The following is a description of a gene set: The chemical reactions and pathways involving alcohols, any of a class of compounds containing one or more hydroxyl groups attached to a saturated carbon atom. species: Mus musculus Mouse Gene Set: GOBP_ALCOHOL_METABOLIC_PROCESS, and this is the list of marker genes: Gpd2, Coq2, Aldh3a2, Acer3, Gfi1, Hmgcs1, Rdh8, Retsat, Hao1 (hydroxyacid oxidase 1, liver), Mapk1, P2ry6, Bmp6, Akr1c18, Gde1, Dgkq, Pmvk, Sphk1, Npc1, Fgfr4, App (amyloid beta precursor protein), Ces1a, Degs2, Gk5, Adh5, Ippk, Pcbd1, Coq3, Acadvl, Pgp, Rdh16, Aldh3b1, Tm7sf2, Saa1, Bmp5 (NCBI Gene Id 12160), Dgat1, Ttc39d, Itpkb, Sult2a8, Akr1cl, Hmgcs2 (NCBI Gene Id 269467), Srebf1, Smpd1, Hsd11b2, Srd5a3, Ptafr, Acer1, Sdr16c5, Fgl1, Cbr4, Fgf1, Tpk1, Ldlr, Park7, Rdh5, Erlin2, Errfi1, Chka, Stard4, Nfkb1, Disp3, Akr1b1, Rdh14, Ces1e, Gnai1, Abca2, Sqle, Vldlr, Inppl1, Hsd17b7, Cebpa, Idh2, Wnt4, Dpm1, Pnlip, Rdh9, Sult2a5, Cyp39a1, Sult1e1, Ephx2, Lmf1 (lipase maturation factor 1), Cftr, Ip6k1, Apoa1, Dolk, Sgpp2, Mvd, Apob, Aldh1b1, Rdh12, Lipe, Nudt3, Gdpd3, Myof, Cyp1a1, Cyp27a1, Sgpp1, Gk2, Ces2e, Rpe65, Pcsk9, Rbp1, Pth, Lss (lanosterol synthase), Rdh10, Ntsr1, Cd244a, Adh4, Npc2, Star, Cyp1a2, Rbp4, Impa2, Plpp1, Ip6k3, H6pd, Lepr, Cyp27b1, Rdh19, Impa1, Aldh2, Abcg1 (NCBI Gene Id 11307), Pck2, Sptlc3, Ces1c, Lipc (NCBI Gene Id 15450), Pth1r, Tkfc, Dhcr7, Pten, Pmp22, Moxd2, ENSMUSG00000144291, Rdh7, Rdh1, Abhd4, Ces2a, Cacna1h, Dgat2, Nudt10, Qdpr, Rest, Sult2a2, Cyp7b1, Sptlc1, Mogat2, Ttc39b, 3110082I17Rik, Lep, Cyp1b1, Serpina12, Dpagt1, Moxd1, Apoa5, Prkaca, Soat2, Plcg2, Thtpa (thiamine triphosphatase), Ces1g, Npc1l1, Isyna1, Dkk3, Sod1, Myh9, Galr2, Naaa, Lrp1, Ppip5k2, Adh1, Akr1c13, Fmo5, Dpm2, Aco2, Akr1c21, Fdps, Ch25h, Agk, Akr1c14, Acp3, Sc5d, Plb1, Pon1, Cyb5r3 (cytochrome b5 reductase 3), Cat, Kcnma1, Aldh1a1, Ldlrap1, Pctp, Itpka, Apoa2, Akr1a1, Sult2a6, Hnf1a, Scarb1, Qki, Msmo1, Ppip5k1, Synj2, Pip4p1, Gykl1, Apoc3, Fkrp, Lhcgr (NCBI Gene Id 16868), Aplp2, Hmgcr, Gpr146, Ednrb, Mbtps1, Sptlc2, Mvk, Prkaa1, Fdxr, Adcyap1r1, Erlin1, Nus1, Pecr, Dhfr, Por, Plek, Rdh16f2, Sult2b1, Paqr3, Ipmk (NCBI Gene Id 69718), G6pdx, Galk1, Prkg1, Sult2a1, Dysf, Apoc1, Cyp7a1 (cytochrome P450, family 7, subfamily a, polypeptide 1), Pou1f1, Fech, Dhdds, Nsdhl, Akr1c6, Tpi1, Itpk1, Ebp, Grk3, Ephx1, Srebf2, Abca1, Rdh13, Mbtps2, Idh3a, Asah1, Plcg1 (phospholipase C, gamma 1), Ces1h, Lrp5, Lipa, Avpr1b, Cyp11b2, Gnb3, Adh7, Idh3b, Snca, Dab2, Miox, Sec14l2, Angptl3, Tnfsf4, Mecp2, Acer2, Thrb, Plcd1 (NCBI Gene Id 97538), P2ry1, Bmp2, Slc5a3, Idi2, Cyp51, Apobr, Tsku, Mttp, Got1, Pla2g4a, Pcbd2, Idh1, Itpkc, Akr1c19, Pts, Cyp2r1, Clcn2, Dhrs3, Gch1, Cyp24a1, Apof, Il4, Sord, Asah2, Plpp2, Akr1c12, Prkaa2, Aqp8, Dpm3, Sult2a4, Adh6a, Insig1, Sdr9c7, Mas1, G6pd2, Ces1b, Rdh11, Fgfr1, Sult1b1, Arv1, Cyp46a1, Gper1, Lrp2, Hsd3b7, Mogat1, Sptssa, Pex2, Idh3g, Abca5, Nudt4, Abcg4, Lrat, Plcb1, Gba1, Scnn1b, Scap, Sult2a3, Pnpla2, Cyp11b1, Aldh1a2, Soat1, Sult2a7, Cyp11a1, Insig2, Apon, Gk, Lima1, Nudt11, Dhrs4, Bco1, Spr, Aldh1a7, Pck1, Dhcr24, Scp2, Akr1c20 (aldo-keto reductase family 1, member C20), Dhrs7, Sptssb, Plpp3, Lpcat3, Cln8, Awat2, Enpp1, Ip6k2, Ces2c, Aldh3b2, Nfe2l1, Adh6b, Dbh, Fdft1, Npy1r, Cubn, Acadl, Aldh1a3, Lcat, 4933405O20Rik, Fdx1, Akr1d1, Idi1, Apoe, Napepld, Apoa4, Ces1f, Ces1d, Plcb3 (NCBI Gene Id 18797), Sphk2, Cln6, Gba2, Lbr, Hsd17b6, Hdlbp, Gdpd1